Given this list of marker genes PPP1R12A, KSR1, YWHAQ (tyrosine 3-monooxygenase/tryptophan 5-monooxygenase activation protein theta), PRKCE, TMCC3, TP53, DDIT4, RIPOR2, ZFP36, NFATC2, ZFP36L1, IRS2, SYNPO2, KLHL22, ESR1 (estrogen receptor 1), CFTR, HDAC7, RIPOR1, HLA-F, TBC1D22A, SIK1, FOXK1, RBM7, PI4KB, TBC1D22B, AKT1, SRPK2, NEK1, AANAT, KIF13B, DAB2IP, RPTOR, here is a description of the gene set: Human Gene Set: GOMF_14_3_3_PROTEIN_BINDING studied in species Homo sapiens Binding to a 14-3-3 protein. A 14-3-3 protein is any of a large family of approximately 30kDa acidic proteins which exist primarily as homo- and heterodimers within all eukaryotic cells, and have been implicated in the modulation of distinct biological processes by binding to specific phosphorylated sites on diverse target proteins, thereby forcing conformational changes or influencing interactions between their targets and other molecules. Each 14-3-3 protein sequence can be roughly divided into three sections: a divergent amino terminus, the conserved core region and a divergent carboxy-terminus. The conserved middle core region of the 14-3-3s encodes an amphipathic groove that forms the main functional domain, a cradle for interacting with client proteins.